Given this list of marker genes ALDOC, ALDOB, HACL1, ARMT1, SGPL1, ALDOA, SHMT1, SHMT2, DERA, here is a description of the gene set: species: Homo sapiens Catalysis of the cleavage of a C-C bond in a molecule containing a hydroxyl group and a carbonyl group to form two smaller molecules, each being an aldehyde or a ketone. Human Gene Set: GOMF_ALDEHYDE_LYASE_ACTIVITY